Given this list of marker genes Junb, Cd74 (CD74 antigen (invariant polypeptide of major histocompatibility complex, class II antigen-associated)), H2-Aa, H2-Eb1, Ccl5, here is a description of the gene set: Cytokines mediate cell-cell communication in the immune system and represent important therapeutic targets. A myriad of studies have highlighted their central role in immune function, yet we lack a global view of the cellular responses of each immune cell type to each cytokine. To address this gap, the authors created the Immune Dictionary, a compendium of single-cell transcriptomic profiles of more than 17 immune cell types in response to each of 86 cytokines (>1,400 cytokine-cell type combinations) in mouse lymph nodes in vivo. A cytokine-centric view of the dictionary revealed that most cytokines induce highly cell-type-specific responses. For example, the inflammatory cytokine interleukin-1β induces distinct gene programmes in almost every cell type. A cell-type-centric view of the dictionary identified more than 66 cytokine-driven cellular polarization states across immune cell types, including previously uncharacterized states such as an interleukin-18-induced polyfunctional natural killer cell state. from publication Cui A, Huang T, Li S, Ma A, Pérez JL, Sander C, Keskin DB, Wu CJ, Fraenkel E, Hacohen N (PMID 38057668) Genes negatively differentially expressed in cell type: CD4+ T cell upon treatment with cytokine: CD40L in mouse lymph nodes in vivo. Mouse Gene Set: CUI_T_CELL_CD4_CD40L_RESPONSE_DN studied in species Mus musculus